The following is a description of a gene set: Genes up-regulated in comparison of B cells from influenza vaccinee at day 7 post-vaccination versus plasmacytoid dendritic cells (pDC) at day 7 post-vaccination. Human Gene Set: GSE29618_BCELL_VS_PDC_DAY7_FLU_VACCINE_UP Systems vaccinology has emerged as an interdisciplinary field that combines systems wide measurements and network and predictive modeling applied to vaccinology. Here we used the systems vaccinology approach to study the molecular mechanisms underlying th from publication Nakaya HI, Wrammert J, Lee EK, Racioppi L, Marie-Kunze S, Haining WN, Means AR, Kasturi SP, Khan N, Li GM, McCausland M, Kanchan V, Kokko KE, Li S, Elbein R, Mehta AK, Aderem A, Subbarao K, Ahmed R, Pulendran B (PMID 21743478) species: Homo sapiens, and this is the list of marker genes: UBR5, CD24, SIPA1L3, TBL1X, PRKD2, EGR1, IFNGR2, IL4R, RHOQ, MBD4, ABLIM1, LY86, STAG3, FCGR2B, RAPGEF6, EAF2, MARCHF8, TENT5C, GVINP1, YBX3, CCR6, MS4A1, FCER2, STAP1, TRAF5, DGKD, ZNF43, PLEKHA2, CDKN1B, BTG1, CR1, DUS2, PHTF2, NUP88, SYNPO, CD79B, VPREB3, BACH2, KIAA0040, RASGRP3, CA5B, LYST, MOB3B, CALM3, CEMIP2, MARCKS, IFITM1, PELI1, EPB41L2, ARHGEF18, DDB2, ARID5B, HES1, TUBA4A, CHMP7, LIMD2, AFTPH, SPOCK2, PLCG2, LINC00623, DENND3, EZR, KDM4C, GABPB1, TUBB2A, TUBA1A, TXNIP, MARF1, NCK2, SNX2, CLEC2D, DOCK9 (dedicator of cytokinesis 9), SLC50A1, BASP1, WEE1, APOL1 (apolipoprotein L1), SWAP70, P2RX5, AMPD3, CDC14B, ST6GAL1, PIK3IP1, TMEM131L, CHD7, PIK3C2B, BMS1P20, WDR11, TPD52, MYC, BIRC3, CDC42EP3, CD55 (CD55 molecule (Cromer blood group)), MTSS1, TRIB2, SP140, CNN2, PDLIM1, ZBP1, CD200, CD37, SSBP2, CKAP2, SP100, SIPA1L1, SS18L2, EVL, PIKFYVE, ENTPD1, CDC25B, IGLV1-44, IGLL3P, FOXO1, TTC9, OSBPL10, ASL, TNFRSF13B, CD69, DDIT3, CDC42SE1 (NCBI Gene Id 56882), TNFAIP8, SMAGP, TAF1D, ALOX5, IKZF3, PAX5, PLEKHF2, BACE2, RHOB, PIK3CA, JUNB, RRAS2 (RAS related 2), IGKV4-1, CD22, GPR18, PTK2B, PLAAT4, IGKV3-20, S1PR1, ICAM3, PPP1CC, ZNF395, IGHD, SYPL1, ADAM28, CD79A, ATM, KLF2, SLC2A3, SKAP1, BANK1, CD83, CD52, CASP4, LBH, P2RY10, SMCHD1, IGKV1D-13, IRS2, ILRUN (inflammation and lipid regulator with UBA-like and NBR1-like domains), USP12, NLRP1, MBD2, CD47, OGA, HK2, LAT2, ATP2B1, ZFP36L1, CDK14, CLIC4 (NCBI Gene Id 25932), IGHM, NT5E, POU2AF1, ADAM8, ADD3, IGLJ3, MYCBP2 (NCBI Gene Id 55685, MYC binding protein 2), GSAP, FCGR2C, BCL2A1, AEN, FCMR, ZNF318, JUN, FCRL2, IFT57, IGKC, CIITA, TRBC1, IL24 (interleukin 24), MAGEF1, HMGB2, CD19, CD72